The following is a description of a gene set: We have used microarray technology to identify the transcriptional targets of Rho subfamily guanosine 5'-triphosphate (GTP)ases in NIH3T3 cells. This analysis indicated that murine fibroblasts transformed by these proteins show similar transcriptomal profiles. Functional annotation of the regulated genes indicate that Rho subfamily GTPases target a wide spectrum of functions, although loci encoding proteins linked to proliferation and DNA synthesis/transcription are upregulated preferentially. Rho proteins promote four main networks of interacting proteins nucleated around E2F, c-Jun, c-Myc and p53. Of those, E2F, c-Jun and c-Myc are essential for the maintenance of cell transformation. Inhibition of Rock, one of the main Rho GTPase targets, leads to small changes in the transcriptome of Rho-transformed cells. Rock inhibition decreases c-myc gene expression without affecting the E2F and c-Jun pathways. Loss-of-function studies demonstrate that c-Myc is important for the blockage of cell-contact inhibition rather than for promoting the proliferation of Rho-transformed cells. However, c-Myc overexpression does not bypass the inhibition of cell transformation induced by Rock blockage, indicating that c-Myc is essential, but not sufficient, for Rock-dependent transformation. These results reveal the complexity of the genetic program orchestrated by the Rho subfamily and pinpoint protein networks that mediate different aspects of the malignant phenotype of Rho-transformed cells. Genes up-regulated in NIH3T3 cells (fibroblasts) transformed by expression of contitutively active (Q63L) form of RHOA off plasmid vector. Mouse Gene Set: BERENJENO_TRANSFORMED_BY_RHOA_UP from publication Berenjeno IM, Núñez F, Bustelo XR (PMID 17213802) studied in species Mus musculus, and this is the list of marker genes: Topbp1, Csnk2a2, Mcm7, Nup107, Errfi1 (ERBB receptor feedback inhibitor 1), Pum3, Dnph1, Traf3, Kif4, Srm, Eif3b, D030056L22Rik, Ngef, Nup50, 1810009A15Rik, Flnb, Dusp6, Phc2, Kpna2, Slc35d1, Polr1e, Slc35e4, Slk, Spdl1, Snrnp40, Ccn1, Acot7, Mcm3, Rfc3, Casp3, Hivep2, Dipk2a, Aqp1, Tamm41, Pfkl, Brip1os, Eed, Bub3, Wdhd1, Prc1, Lrrc8c, Gart, Utp18, G6pd2, 2310061I04Rik, Racgap1, Dhfr, Eif2s1, Hsp90aa1, Gpn1, Bnc1, Ccnf, Mrps10, Pvr, Arl4c, Stmn1, Pmf1 (NCBI Gene Id 99883), Ube2t, Sephs2, Ccl2, Chrnb1, Tfdp1, Kif2c, Chd1, Usp1, Mcm4, Rad51ap1, Serpine1, Ranbp1, Tnnt2, Actg2, Ddx21, Cacybp, Odc1, Hspa4, Ttk, Ngf, Cib1, Cdc20, Mcm2, Rbl1, Gtse1, Chaf1b, Acta1, Kpnb1, Anxa3, Fkbp2, Plk2, 1810037I17Rik, Ei24, Irgm1, Ccna2, Psmd11, Usp10 (ubiquitin specific peptidase 10), E2f1, Clcn3, Shmt1, Nup62, Atp1b3, Runx1, Mybl2, Tcerg1, Fbl, Lamc2, Snrpd3, Tacc3, Mrps22, Ppp1r14b, Ppa1, Acot9, Cstf2, Fkbp4, Cdc45, Gar1, Gk, Timm8a1 (translocase of inner mitochondrial membrane 8A1), Ptcd3, Pimreg, Dtymk (deoxythymidylate kinase), Nmt1, Trim59 (tripartite motif-containing 59), Nop2, Ckap2 (NCBI Gene Id 80986), Psmb3, Psma7, Gdnf, Rabggtb, Pbx3, Ipo7, Saa3, Hat1, Hpf1 (NCBI Gene Id 72612), Hsph1, Ncbp1 (nuclear cap binding protein subunit 1), Txnrd1, Eif3j1, Fam110a, Otud4, Rars1, Grpel2, Htra1, Nr1d2, Hk2, 2700099C18Rik, Mrto4, Uba2, Dctpp1, Myc, Ptpre, Klra4, Dnajc9, Cmtr2, Suz12, Phldb2 (NCBI Gene Id 547265), Nubp1, Exo1, Adam12, Tomm40, Srsf1, Tdp2, Fam162a, Slc2a1, Nusap1, Tyro3, Rpa1, Ptger4, Timm23 (NCBI Gene Id 53915), Cdca7l (cell division cycle associated 7 like), Ivns1abp, Zftraf1, Epha2, Tcf19, Fhl1 (NCBI Gene Id 14199), Tyms, Abce1 (NCBI Gene Id 96976), Smc2, Bax, Tardbp, Sqor, Naa15, Mtmr10, AU020206, Top2a, Nop16, H2-D1, Pcna, Cct3, Prdx6, Orc1, Pnpt1, Cytip, Snrpd2, Rprd1b, Mad2l1, Kcnk2, Rbm14, Gm4739, Ppid (peptidylprolyl isomerase D (cyclophilin D)), Psmd13, Cdc25c, Has2, Bdnf, Nsmce4a, Mcm10, Piga, Ect2, Prim1, Cdk1, Actn1, Kif22, Ran, Ak4, Slbp, Mis18bp1, Rpl32, Kif11, Plekha1, Nhp2 (NHP2 ribonucleoprotein), Anapc15, Jun, Fez2, Gclm, Coro1c, Hmgb3, Gsto1, Raet1d, Pfdn6, Erdr1, Msln, Sinhcaf, Bop1, Nfkbia, Polr2e, Lin7c, Rrs1, Rbmxl1, Pdlim1, Pcid2, Sod2, Dusp9, Dusp1, Grk6, H2az1, Cavin2, Tmem176b, Orc6, Cse1l, Gm4870, Kifc1, Rrn3, Gsr, Specc1, Lsm2, Pola1, U90926, Lbr, Snrpd1, Emg1, Etf1, Incenp, Phtf2, Net1, Gapdh, Ipo11, Cxcl5, Bola2, Ptgs2, Tubb6, Fosl1, Foxm1, Tpgs2 (tubulin polyglutamylase complex subunit 2), Fignl1, Trim17, Tfrc, Nid1 (NCBI Gene Id 268621), Nedd4l, Cenpv, Phlda1, Xpo1, Nup85, Nudcd2, Gsdme, Zfp53, Nup54, Pttg1 (NCBI Gene Id 98125), Fam171a1, Trip13, Rnaseh2a, Mrpl16, Mycn, Tom1l1, Col8a1 (collagen, type VIII, alpha 1), Tmem176a, Tk1, Dhrs7b, Rrm1, Ereg, Uhrf1, Prim2, Lsm3, Taf1d, Kif23, Ahcyl, Rpp30, Cdca4, Tnk2, Mcm5 (NCBI Gene Id 194478), Mrpl18, Ldha, Dtl, Rnps1, Mrpl12, Il1rl1, Igf2, Eif2b2, Itga6, Hmga2, Stip1, Ruvbl2, Ttc27, Plk4, Ddx18, Asf1b (NCBI Gene Id 66929), Pprc1, Sf3a3, Mdm2, Aimp2, Lrrc59, Zfand2a, Banf1, Hars1, Ggct, Diaph3 (NCBI Gene Id 80466), Gja1, Ezh2, Uchl5, Dek, Pkia, Thy1, Lsm4, Tomm70a, Haus6, Ccn2, Wdr43 (NCBI Gene Id 72515), Adora2b, Mrpl34, Cks2, Ssrp1, Tsr1, Trp53, Cdc34b, Ifit2, Nop58, Ifrd1, Timeless, Grem2, Pola2, Rcl1, Grwd1, Vegfa, Anln, Cdca8, Fen1 (NCBI Gene Id 14156), Prl2c2, Rad51 (RAD51 recombinase), Ftsj3, Ier3, Actn4, Cd44, Hmgn5, Lig1, Bpgm, Pla2g4a, Cd93 (NCBI Gene Id 99415), Esf1, Cip2a, Lats2, Haus3 (HAUS augmin-like complex, subunit 3), Mthfd2, Nectin2, Npnt, Abcf2, Msn, Casp8ap2, Psmb5, Igfbp6, Gpd2, Gbe1, Cbx5, Rcc1, Ezr, Tmsb4x, Dnajc2 (NCBI Gene Id 22792), Tes, Bub1, Sorbs1, Pkp4, Coq7, Macroh2a1, Slco3a1, Slc11a2, Snrpa1, Dna2, Timp1, Dpysl3, Efnb2, Rfc5, Cdkn1a, Lrrfip1, Frat2, Plscr1, Rrp12, Thbd, Ifrd2, Arl14ep, Slc4a4, Usp14, Nppb, Vars1, Btg3, Rfc4, Ccl7, Mak16, Mrps25, Pon2, Brca1, Cks1b, Adm, Nsun2, Tnc (tenascin C), Nup93, Iqgap3, Nfkbiz, Cdk8, Chek1, Ipo5 (importin 5), Rnaseh2c, Hells, Ankrd1, Utp4, Ccnd1, Cbx1, Tipin, Uck2, Lin9, Tgif1, Tmem97, Pclaf, Nasp, Cfl2, Nxt1, Ptges3, Foxc2, Ccng1, Spp1, Alyref, Pa2g4, Gadd45a, Psmc2, Gmnn, Ybx3, Rbm38, Ss18, Bysl, Pold1, Klf4, Dck, Tubg1, Sap30, Polr3k, Psat1, Hbegf, Tbl3, Cdc7, Alcam, Eif6, Plaur, Higd1a, Txn1, Znrf2, Cdc6, Aurka, D17H6S56E-5, Pgk1, Pno1, Rangap1, Cdr2, Pole2, Esd, Tnfaip3, Hprt1, E2f8, Schip1, Cd151, Slc66a3, Psma1, Taldo1, Mki67, Birc5, Cycs, Get3, Cox17, Rpf2, Phf5a, Procr, Ndufaf4, Capg, Gpc1, Cdca5, Vrk1, Dlgap5, Kif20a, Ebna1bp2, Cenpa, Slc30a4, Mapk6, Dnmt1, Lsm8, Fam136a, Diaph1, Haspin, Actl6a, Hspa14, Zfpm2, Pgam1, Cxcl1, Smc4, Rflnb, Inhba, Nr4a1, Nme1, Rsl1d1, Ly75 (NCBI Gene Id 17076), Ell2, Cinp, Msh2, Smoc1, Tpi1, Sae1, Dnajc21, Rangrf, Nek2, Tagln, Nde1, Sf3b5, Retreg1, Hspd1, Acsl5, Cct7, Tagln2, Ackr3, Aurkb, Cdca7, Aspm, Cisd1, Bcat1, Hspa4l, Tmpo (NCBI Gene Id 71450), Thbs1, Ctps1